Given this list of marker genes Ptprz1, Stxbp2, Snap25, Csf1, Vamp2, Csf1r, Casp3, Stx3, Stx4a, Stx1a, Sdc1 (syndecan 1), Il16, Txlna, Il34, Cd4, here is a description of the gene set: species: Mus musculus Other interleukin signaling Mouse Gene Set: REACTOME_OTHER_INTERLEUKIN_SIGNALING